Given this list of marker genes RAB4A, SNAPC2 (small nuclear RNA activating complex polypeptide 2), IKZF1, PSMB7, THRB, HTR1A, GCNT1, SORD, NXN, ARAP3, LY86, VTN, DIABLO, TINF2, RTN1, MRPS10, FOXA3, HINFP, NFATC3, SIRT2, CDCA7L, TCOF1, NUBP1, UROD, PTGER1, HIF3A (NCBI Gene Id 93988), RAB23, ADGRE5, CYP1A1, BTF3, NDUFB8, GFI1, PDPN, HCCS, CNGA1, PLEKHO1, ARHGAP9, SKIL, POLR1C, C6orf136, HARS1, CAPZB, CDC34, AOAH, ELK3, CAMSAP1, HS3ST3A1, SGO1, EYA2, S100A9 (S100 calcium binding protein A9), CEBPD, MSR1, CST9L, ITGAX, TSPAN32, HPCAL1, AFF4, CHMP6, PTPRJ, REX1BD, TBRG4, IER2, KPNA4, CD81, ZNF354A, PSMD4, PDLIM4, SLC7A7, ZNHIT2, KCNA3, SRPRB, TRDMT1, CBR3, BRWD3, TSPAN5 (NCBI Gene Id 10098), CTSW, NRCAM, ADAMTS1, GFER, SLC4A7, HSD3B1, DNAAF10, SERPINA10, UCK2 (NCBI Gene Id 7371), NSF, CPSF4, RND2, ELP3, RPP14, NDRG3, VTI1A, PDIA3, INO80C, IL7, SNX12, TMEM131, NSUN4, ZCCHC10, PKN2, CDKN1B, PRIM2, GEM, DNAJC3, GRK2, C15orf39, ARNT, TSR1, ELL, PITHD1, EIF4ENIF1, FAM220A, AK2, MRPS15, IFI27, PLXND1 (NCBI Gene Id 23652), TOP3B, RRP1B, DDX21, TYMP, ADRB2, ST3GAL2, NT5C3B, ACSL4, SEBOX, PAPSS2, MSL2, ACTR1B, RTL6, CTR9, KIAA2013, THBS1, RAB8B (RAB8B, member RAS oncogene family), ITGA4, GPR137B, EMC3, MBD4, RWDD1, RFK, RASSF5, DGUOK, ZBTB25, DDX3Y, CYBB (cytochrome b-245 beta chain), CCNB1IP1, PARG, POLE4, PRRC1, B3GALT4, MOB2, UBL4A, NCF1, EIF2AK1, CCR2, ACP5, CD52, DBT, RHOH, CDC42EP4, DCTN3, WNT3, NPY (NCBI Gene Id 4852, neuropeptide Y), PRMT3, SRP9, GBA1, DDX3X, MRPS11, MECR, SDHC, RNH1, DDX10, ERF, CLTA, DKK3, C1QB, NR3C1, GNG12, GPR132 (G protein-coupled receptor 132), TUSC2, DAGLB, ST6GALNAC1, ERP44, NAA38, GDPD3, PTPN6, SLC35C2, CD72, RBL1, SH3BP2, NFKBIE, NUP93, SLC66A3, NECAP2, UBE2F, FBXO21, GK, ENY2, DNASE1L3, RAB7A, ADAR, LHX3, here is a description of the gene set: Human Gene Set: GSE43955_1H_VS_42H_ACT_CD4_TCELL_UP from publication Yosef N, Shalek AK, Gaublomme JT, Jin H, Lee Y, Awasthi A, Wu C, Karwacz K, Xiao S, Jorgolli M, Gennert D, Satija R, Shakya A, Lu DY, Trombetta JJ, Pillai MR, Ratcliffe PJ, Coleman ML, Bix M, Tantin D, Park H, Kuchroo VK, Regev A (PMID 23467089) Despite their enormous importance, the molecular circuits that control the differentiation of Th17 cells remain largely unknown. Recent studies have reconstructed regulatory networks in mammalian cells, but have focused on short-term responses and relied on perturbation approaches that cannot be applied to primary T cells. Here, we develop a systematic strategy – combining transcriptional profiling at high temporal resolution, novel computational algorithms, and innovative nanowire-based tools for performing gene perturbations in primary T cells – to derive and experimentally validate a temporal model of the dynamic regulatory network that controls Th17 differentiation. The network is arranged into two self-reinforcing and mutually antagonistic modules that either suppress or promote Th17 differentiation. The two modules contain 12 novel regulators with no previous implication in Th17 differentiation, which may be essential to maintain the appropriate balance of Th17 and other CD4+ T cell subsets. Overall, our study identifies and validates 39 regulatory factors that are embedded within a comprehensive temporal network and identifies novel drug targets and organizational principles for the differentiation of Th17 cells. Genes up-regulated in CD4 T helper cells Th0: 1h versus 42h. studied in species Homo sapiens